The following is a description of a gene set: studied in species Homo sapiens Developmental processes. Human Gene Set: MODULE_220, and this is the list of marker genes: MYBPC2, NHLH2, ANPEP, LMO2, CPZ, ALX1, NGF, GFRA3, NRG2, PDGFRB, CLC, HOXA5, NELFA, DHH, SEMA4D, CDC42EP1, DCT, RARG, LMO1, IGF1, GATA1, APBA1, LAMC2, GJB1, PPP2R5D, CSF1, TNNI2, ARHGDIB, DRP2, EGF, FOXG1 (forkhead box G1), MEF2D, NPAS1, UGT8, KRT85, UTRN, KRT17, KIT, MID1, CSRP2, EFNB3, CAV3, EDN3, CELF2, LAMA3, NTRK2, CCN2 (cellular communication network factor 2), TGFBR3, BMP1, HOXD13, IL11, EYA1, JAG1, EVPL, PDCD1, SPOCK2, HBEGF, CASP14, TBX5, MDK, NNAT, LCE2B, EPHB2, PAEP, MYH11, LRCH4, S100A1, ASIC2, DPYSL4, TBR1, NTN3, EPHB1 (EPH receptor B1), EFNB1, CBLN1, FGF12, TLX1, POU4F1, EDA, SIX6, LAMA2, GRB7, PTPRR, RND1, ERBB2, EPHA2, DVL1, IL3RA, SEMA7A, HLF, NEURL1, ISL1, CD4, ANGPT1, KRT14, MSI1, NTRK1, PMP22, CHRM1, WNT7B, DLG4, ZIC1, FHL1, PAX6, TFAP2A, ELF3, ADRA1D, CD3G, GJA1, AMELX, SH3GL2, DLK1 (delta like non-canonical Notch ligand 1), FGF1, SPOCK1, KRT15 (NCBI Gene Id 3866), ID1, MMP11, KRT6A, IL6R, KRT2, PTPRG, LIF, ANKRD7, SERPINI1, SIX1, TLX2, ARTN, NGFR, IGF2, KRT13, LEPR, TNFSF12, COL6A3, DLX5, BDKRB2, ITGB5, CXCL8, RAPGEF1, EPHA4, ACTA2, ACTG2, NDN, KRT16, HOXB8, WFS1, FZD9, AMELY (NCBI Gene Id 266), CTF1, HMGA2, DPYSL2, EPHB6, MEF2C, ZP2, ACKR2, MAP4K1, GHR, TBXT, FRZB, FLT1, SOX9, HOXC11, ENC1, PRRX2, FGF7, CXCR4, NRG1, AKAP3, CRABP1, EDN2, MYBPC1, S100A4, PLXNA3, MGP (matrix Gla protein), NKX2-8, S100B, ROR2, MYOM1, ANOS1, DOK1, EPAS1, SLIT3, HOXD10, COL1A1, GAP43 (growth associated protein 43), FGF2, CD8A, PDGFRA, PAX5, TAFAZZIN, TBX1, AQP4, CDX1, ADARB1, KRT5, NELL1, POU3F1, RTN1, MATN1, ADAM12, EREG, KRT6B, EMP2, GPR65, ROR1, ROS1, FZD2, TNNT3, FLNA, NPTX1, FGF5, GLRA1, CXCL1, TNFAIP2, NKX3-1, PAX2, BST1, SERPINF1, COL11A1, HOXB2, NRTN, IL3, ZEB2, GSTP1, HOXB5, CRABP2, MYBL2, EGR2, SIM2, EFNB2, ADAM23, COL7A1, TFAP2B, KRT32, CXCL10, DDR2, FGF11, AEBP1, ITGB7, SEMG1, HOXA4, STMN2, MSX1, TBX4, SPEG, ID3, RECQL4, PTN, CDX2, NRP1, WNT10B, FOXE1, GRIK1 (glutamate ionotropic receptor kainate type subunit 1), TBX2 (T-box transcription factor 2), MYL4, GREM1 (gremlin 1, DAN family BMP antagonist), SPRR1B, ALDH3A2, CHRNA4, BST2, EPHB3, PCP4, LDB2, EMP3, CYP1B1, EFNA5, ACTC1 (NCBI Gene Id 70), LUM, ADORA1, WNT5A, POU6F1, EPS8, CAPN3, FHL3, NEO1, RELN, DPYSL3, PBX1, CRCP (CGRP receptor component), APOE, PI3, ITGB2, PTMS, CD8B, AR, NRGN, SIX3, CPNE6, MYOG, LAMB3, WNT2, SNAI2, SCRG1, KRT9, FBN1, CSF3, GJB5, MST1R, CCL17, MEOX1, FEZ1, DLX3, MAL, CD40, FABP7, NAB2 (NGFI-A binding protein 2), LHB, PLOD1, ARVCF, HOXD8, SEMA3C, CSRP3, PAX7, GLI1, MFNG, CRMP1, TLE1, LY6H, EMP1, TEK, SEMA3A, KRTAP5-9, L1CAM, IL6 (interleukin 6), TCL1A, HOXB1, EDNRB, LEFTY1, IRAG2, GLI3, ST8SIA2, CALD1, PRL (NCBI Gene Id 5617), PAX9, GCM2